Given this list of marker genes XPO4, PCDH8, ITSN2, ANK1, WDR26, SALL1, NRP2, SP8, DMD, TOGARAM1, TBC1D19, SLC30A7, TMEM47 (transmembrane protein 47), SCYL2, DCUN1D5 (defective in cullin neddylation 1 domain containing 5), RPS6KB1, UBFD1, CREBRF, FURIN, KDM5C, UBQLN2, ATL1 (atlastin GTPase 1), ARK2C, WT1-AS, NR4A3, MIR1915HG, STMN1, SLITRK4, SRSF1, ZFAND6, MMP16, TSHZ3, AKT3, KIF1B, METRNL, SLC6A10P, SAV1, ATP2B2, IQSEC2, RPGRIP1L, UNC5A, C5orf24, CLK3, PPP2R5E, LINGO1, ANK3, AFF2, ATP2C1, SP3, PLCB4, RAI14, TRPS1, SORCS1, DOCK9, PCNX2, CACNB2, SORBS2, SAR1B, BNC2, DOC2A, MIP, PCDH9, XPNPEP1, RFX1, ZIC1, PHC1, BOLA2, DIXDC1, SH3BGRL, THRB, TRIM67, NIN, CHEK1, NKX2-2, PRND, MIB1, CLK2, DIAPH1, SYN3, KCNIP4, SEPTIN4, PHF6, CNTLN, SEPTIN7, SGIP1, ATP8B5P, KCNMB2, NKAIN2, MAB21L1, GRIA3, DBT, LRCH2, EPHB1, UXS1 (NCBI Gene Id 80146), SCN8A, GGT7, ZEB2, MBNL1, DGKH, MFF, RAB8B, ARID4B, HDGF, CHD9, DAZAP2, CD2AP, CCN1, LENG8, CHRD, here is a description of the gene set: Genes having at least one occurence of the motif TGCAAAC in their 3' untranslated region. The motif represents putative target (that is, seed match) of human mature miRNA hsa-miR-452 (v7.1 miRBase). Human Gene Set: TGCAAAC_MIR452 species: Homo sapiens